The following is a description of a gene set: studied in species Mus musculus The chemical reactions and pathways resulting in the formation of monosaccharides, polyhydric alcohols containing either an aldehyde or a keto group and between three to ten or more carbon atoms. Mouse Gene Set: GOBP_MONOSACCHARIDE_BIOSYNTHETIC_PROCESS, and this is the list of marker genes: Eno2, Aldob, Gpd1, Nln, Fbp2, Ddb1, Gapdhrt, Car5a, Mtcl2, Atf3, C1qtnf12, Pdk2, Gcg, Per2, Slc37a4, Sirt7, Akr1a1, Kat2a, Wdr5, Sirt1, G6pd2, Pgam2, Chst15, Kat2b, Usp7, Supt20, Gnmt, Adipoq, Prkag2, Tcf7l2, Slc25a13, Crtc2, Mst1, Akr1b1, Lepr, Acadm, Gsto1 (glutathione S-transferase omega 1), Sik1, Prkag1, Atf4, Dgat2, Ogt, G6pdx, Ugt1a6a, G6pc1, Mup2, Sord, Sirt6, Pcx, Lep, Ep300, Ppp4r3a, Dgkq, Gpt2, Mup4, Nr3c1, Gpt, Mdh2, Pfkfb1 (NCBI Gene Id 18639), Gnpda1, Serpina12, Prkag3, Gapdhrt2, Erfe, Slc25a10, Xpc, Hif1a, G6pc3, Sds, Tpi1, Obp2a, Oprm1, Mup1, Slc25a11, Eno1, Gck, Ppara, Stk11, Mup3, Pgp, Ranbp2, Mup11, C1qtnf3, Cry1, Zfp692, Gpd2, Prkaca, Pgk2, Pgd, Pck2, Arpp19, Aldoc, Rbp4, Foxo1, Fbp1, G6pc2, Rgn, Mup5, Nnmt, Gapdh, Gulo, Sesn2, Pck1, Ptpn2, Ppp4r3b, Cyp2j6, Clk2 (NCBI Gene Id 99827), Slc39a14, Ppargc1a (peroxisome proliferative activated receptor, gamma, coactivator 1 alpha), Slc35b4, Pgam1, Pgk1, Got1, Mdh1, Il6, Hnf4a, Gpi1